Given this list of marker genes SCNN1G, SCNN1A, SCNN1D, RANGAP1, CDC6, SCNN1B, PLCB1, ADCY6, here is a description of the gene set: studied in species Homo sapiens Human Gene Set: GOBP_RESPONSE_TO_VASOPRESSIN Any process that results in a change in state or activity of a cell or an organism (in terms of movement, secretion, enzyme production, gene expression, etc.) as a result of a vasopressin stimulus.